Given this list of marker genes RND1, RAC1 (NCBI Gene Id 5879), SEMA4D, ARHGAP35, PLXNB1, RRAS, MET, RHOA, here is a description of the gene set: species: Homo sapiens Human Gene Set: REACTOME_SEMA4D_MEDIATED_INHIBITION_OF_CELL_ATTACHMENT_AND_MIGRATION Sema4D mediated inhibition of cell attachment and migration